The following is a description of a gene set: Human Gene Set: MIR548BB_5P Genes predicted to be targets of miRBase v22 microRNA hsa-miR-548bb-5p in miRDB v6.0 with MirTarget v4 prediction scores > 80 (high confidence targets). from publication Chen Y, Wang X (PMID 31504780) species: Homo sapiens, and this is the list of marker genes: NOS2, ZNF148, NR2C1, NUP54, FZD5, KLRD1, KPNA4, EXOC5, TFDP3, PRKG1, FLRT3, GPATCH11, NDFIP2, LPP, GPC6, DUS4L, FAM221A, ODAPH, GAPVD1, ZNF608 (NCBI Gene Id 57507), MZT1, RHPN2, ACBD5, DIP2B, KATNBL1, TMEFF2, SERINC5, FAM199X, OAZ1, MTMR6, ARL13B, TRPC5, BNIP3, YIPF5, ARFRP1, REV3L (REV3 like, DNA directed polymerase zeta catalytic subunit), MCF2L2, MIER3, ELL2 (elongation factor for RNA polymerase II 2), ANAPC1, SMAD9, TMTC1, CCDC179, LRP1B, LANCL1, ZNG1E, SCN8A (NCBI Gene Id 6334, sodium voltage-gated channel alpha subunit 8), BBX, ZNG1C, EDIL3, MINDY2, CMPK2, LARP4, GRID2, DYNC1LI2, TRIM9, PAQR9, KLF10, ALG11, RPS6KA5, AK3, ZBTB10, MFSD8, DENND1B, KLF8, CBX3, SKIDA1, AFTPH, TIFAB, ZNF559, WDR26, COL11A1, CAPN2, MTA1, CFDP1, CIAO2A, SMG1, ZNF680, THSD7A (thrombospondin type 1 domain containing 7A), BMI1, C21orf91, DTWD2, JARID2 (NCBI Gene Id 3720), GPR155, FYB2, SPOCK3, CCNY, NUMB, TMEM65, STEAP2, NEDD4L, GCC2, EPHA3, ANKRD10, PDE1C, HIPK1, MIER1, SEC22C, FNDC3B, TMEM200A, SECISBP2L, NRG4, PGAM1, KRT28, MEX3D, DYNC1I2, PPP1R9A, GPD2 (glycerol-3-phosphate dehydrogenase 2), ANKRD26, SRSF6, GPALPP1, GUCY1A2, CEP350 (centrosomal protein 350), KIAA1586, ACADL, FRMD5, A1CF, SESTD1, WDR7, MMD, C5orf24, SAMTOR, GRM7, PDCD5, SFT2D1, SMAD5, MAST4, RBBP8, MBIP, TCF12, SLC30A5, SCN3A, SDC2, TMEM255A, FAM135A, ZBTB41, ADAM30, CNTN1, TRAM1, LSAMP, AFDN, PAPOLG, RAP2A, SCN1A, UBE2A, FMNL2, UBA6, MBNL2, ARL6IP6, ZNF486, RGPD6, U2SURP, NRXN1, ADH5, METTL6, GABPA, SH3D19, SRSF3, CA8, GPR85, DDIT4, FOXG1, SNX30, LACTB2, SUMF1, POLR2H, RETREG1, DNAJB14 (NCBI Gene Id 79982), SEC24A, PDZRN4, CCNB1, SPAG9, NDC1, CRIPT, RHOQ (ras homolog family member Q), SETD2, ZBTB25, GATM, ABI3BP, CHN1, TRUB1, BOD1L1, RIMOC1, NUP160, SLAIN1, MGARP, ZDHHC2, LATS1, MFN1, UEVLD, METTL8 (NCBI Gene Id 79828), UTP3, ZNG1F, UGT8, TMEM167B, TMEM135, DIAPH3, IGF1, PRELID2, PCDH11X, NFAT5, PDE4D, ZRANB2, RGS7BP, TNFRSF21, SYTL5, FAM133A, LRRC4B, CAMSAP2, TP53INP1, C9orf40, LCTL, ZNF326, RASSF8, IGF2BP3, PPP1R2, AQP3, DCDC2, RGPD4, DAAM1, BRWD3, CHORDC1, PRKAA2, ZEB2, TMTC3 (transmembrane O-mannosyltransferase targeting cadherins 3), SLC24A3, NUP50, IGSF3, ZNF492, BCL2L2, ANKRD22, PSMC2, GOPC, CSNK1D, CSGALNACT2, ARRDC4, SREK1, LVRN, ARMCX3, FGL2, SLCO5A1, PPHLN1, FIGN, CLVS2, EPB41L5, ATXN7L1, LMCD1, CACUL1, EIF2AK2, DPY19L3, LACTB, RAB8B, CHRNA7, SLC4A7, MECP2, ACTN4, PREX2, GLIPR1, RAP1A, FBXL3, HOMER1, ACBD3, ZNF747, ATP11A, RFX7, ETF1, ANGEL2, PRP4K, SRP9, PPP1R27, SPATA6L, S1PR1, FGFR1OP2, MEIS2, FNIP2, SNX16, SIX4, IKBIP, SANBR, STXBP5, CARF, ME1, PTPRR, MAST3, ADAMDEC1, ZNF503, MIDEAS, MMUT (NCBI Gene Id 4594), RGPD8, NOTCH2, BTF3L4, GRIP1, BEND7, CBFB, MMP16, PLEKHG1, CLDN12, CISD2, TLCD4, CAMLG, GSE1, ZNG1B, TTC19, ACVR2B, ZBTB20, PROK2, LRRTM3, ZDHHC15, IKZF2, B3GALT5, PRPF40A, C3orf38, RNF138, KL, ZFAND5, AHSA2P, FZD7, RO60, ZCCHC8, ZBTB11, BTG2, RORA, AIDA, XPNPEP1, DOLPP1, APPBP2, SCAMP1, HDAC9, MTF1, GULP1, SERINC3, CHST9, MAGT1, CTNNA3, TPM3, RAB27B (RAB27B, member RAS oncogene family), SPDYE1 (speedy/RINGO cell cycle regulator family member E1), TFAM, NTF3, GCNT1, RRAGD (NCBI Gene Id 58528), FGD4, WDR47, KCNJ3, TMED7, ABCA5, MED6, UGDH, TRPC1, CERS6, HMBOX1, TXLNG, RALA, PLEKHH2, RFC3, SYNM, SNAP91, SSR3, HOOK3 (hook microtubule tethering protein 3), ERC2, GNAQ, SLU7, MTFR1, PIWIL3, DEFA6, ANKRD46, EVI2A (ecotropic viral integration site 2A), GUCY1B1, HLTF, PTBP3, PARD3, ZNF792, MAP9, CD163, NAA30, OGFRL1, SOX5, MARCHF6, RMND5A, FSBP, HNRNPDL, NOTUM, MPHOSPH8, CFL2, PPEF2, PCDH11Y, PRRC1, PHYHIPL, GRM5, RIC1, ZNG1A, TTC13, CYBRD1, CRACD, AP1AR, CACNA2D3, DHRS1, CCDC117, ATXN2, SCARF1, MDFIC, UNC80, MBNL3, RNF149, PCLO, SAMD8, PTPRG, CFAP44, TRA2B, PGRMC2, PPARG, PTGFRN, KIF20B, RGPD5, ITGAV, RICTOR, DNAJB4, ARK2N, PITX2, HOXD13, PPP5C, NAT1, LRRC7, COMMD3-BMI1, MIGA1, AGTR1, LCOR, SENP1, RC3H1, ZC3HAV1L, ZBTB44, MYCN, ADAMTS1, MAP4K4 (NCBI Gene Id 9448), LIN7A, CDK6, PROSER1, SDF4, URI1, KLF7, PRKAA1, GABPB1, GASK1A, TOLLIP, CLCN4, FZD3, ZNF454, CD99, HECA, TBCK, ITGB6, PRKAG2, CCP110, ARID2, GSTCD, SACS, TRIM2, GOLGA6L2, SDE2, BBS10, ADAM22, C11orf87, FEM1C, CCDC50, ZDHHC21, NAV2, ACAT2, EEA1, BRWD1, PAX5, STYX (NCBI Gene Id 730432), NFKB1, NCKAP1, CCNG2, C6orf120, SCML2, ONECUT2, RNF217, GTF3C3, NEGR1, HTR2C, SF3A1, TBCA, RESF1, GABRA4, ADGRB3, WAPL, SFMBT1, ZNF652, LMX1A, ASB3, MAML1, CEP120, CCDC47, CCSER1, DUSP7, POU2F1, BTG3, PRPF39